Given this list of marker genes Apex1 (apurinic/apyrimidinic endonuclease 1), Ptbp1, Xrcc3, Dna2, N4bp2, Rad50, Mre11a, Fan1, Slx1b, Dnase2b (NCBI Gene Id 99669), Aste1, Exo1, Dclre1c, Dnase1l2, Dnase1, Dffb, Xrcc4, Dnase2a, Aplf, Endog, Polq, Mus81, Gen1, Bivm, Rbbp8, Dicer1, Endov, Xrcc1 (X-ray repair complementing defective repair in Chinese hamster cells 1), Rad51c, Fen1, Exog, Dnase1l3 (NCBI Gene Id 13421), Ercc1, Zranb3, Ercc4, Eme1, Rps3, Setmar, Eme2, Ercc5, Ankle1, Rag1, Dnase1l1, here is a description of the gene set: Catalysis of the hydrolysis of ester linkages within deoxyribonucleic acid by creating internal breaks. Mouse Gene Set: GOMF_DNA_ENDONUCLEASE_ACTIVITY species: Mus musculus